Given this list of marker genes RNF138, MSI2, CTDSPL2, RAPH1, AAK1, TMEM236, DOP1B, SETD5, MTCL1, NYAP2, BMPR2, PLAG1, LATS1, KAT6A, RECK, ARIH1, XRN1 (5'-3' exoribonuclease 1), ARID1A, ANKRD10, SS18, PTGES3, SLC27A3, CREB1, ANOS1, KIF13A, ABI1, ZW10, METTL15 (NCBI Gene Id 196074), ZNF737, TMEM230 (NCBI Gene Id 29058), VDAC1, HSPD1, PPP5C, PTPRA, NT5C2, RASAL2, BCL11A, MAPK1, SHANK2 (NCBI Gene Id 654128), PRR15L, ZBTB18, FAM218A, SSR1, OCRL, PRPF39, SPG11 (NCBI Gene Id 80208), HOOK3, CAMKK1, NCAPG2, DNAJC6, NECAB1, GPR82, KRAS, TUBB2B, RPS6KB1, STK3, CHMP4B, CHRNA5 (cholinergic receptor nicotinic alpha 5 subunit), VKORC1L1, MAN2A1, TMOD2, LSMEM2, CPNE8, DCK, LRP1B, SFT2D1, APPL2, PDE4D, SCG2, ATP1A2, CAMSAP2, TGFBR3, ENTPD7, CDC73, ONECUT2, APC, TNFRSF19, PTPRD, ABL2, MYOCD, SPTY2D1, CUL2 (cullin 2), HECTD3, DYNC1H1, INPP5B, TAF1, MRPL51, SEC24A, ITM2B, SCAMP1 (secretory carrier membrane protein 1), MAPK10, GFPT1, PDS5B, KLHL5, ACP6, PRICKLE2, PPFIA2, TRIM33, EMP2, RNASE4, GAPVD1, SRSF10, CACNB4, STEAP2, TLCD4, SCAI, MSX1, METAP1, EIF4E, UBE2D2, NLK, PPP4R3A, SNX10, GRIK2, SLC12A2, RPS6KA3, YBX1, PDE7A, CCND3, CCDC102A, ADAMTS3, INO80D, TFPI2, IPO4, ZNF367, CASK, TGFB2, INTS12, TLE4, SLC23A2 (solute carrier family 23 member 2), DAB2IP, TSPAN13, CCSER1, PEG3, ZNF569, CNR1, GCLC, CDH8, CYP27C1, TBC1D19, TMCO3, MAPK8IP1, CAPZA2, REEP1, EDDM3A, HSPA13, RAB33B, NEK7, PPP1R8, ARSJ, LARP6, TRA2B, CHUK, LHX6, PRDM12, SAFB, MOB1B (NCBI Gene Id 92597), PPP1R1B, ELOVL6, ZNRF2, SGIP1, ATAD2B, ZC3H12C, KLHL24 (kelch like family member 24), SLC2A13, BZW1, RASSF8, THAP5, KHDRBS2, PPIE, ANKRD44, FOXO1, ALDH1A3, ZNF281, IKZF5, KCNN4, ADAMTS5, KLF4, RIMKLB, RNLS, MAMLD1, PTCH1, DLGAP1, UCHL5, STON2, ETV1, TAX1BP1, NAMPT (nicotinamide phosphoribosyltransferase), HMGB3, C2CD5, JMY, EIF4G2 (NCBI Gene Id 1982, eukaryotic translation initiation factor 4 gamma 2), LIPF, ZNF681, PTPN13, HAPLN1, NCSTN, PRSS12, HYCC2, ST6GALNAC3, NEGR1, COL11A1, SALL1, GLCCI1, FNDC3B, CTNNB1, NIF3L1, SV2B, C17orf75, RRM2, NT5DC1 (5'-nucleotidase domain containing 1), ZNF780A, ZIC3, EEA1, PSME4, VASH2, RAB5A, SCAP, RPGR, MEGF10, PPP6R3, ARFGEF1, COPS5, CCSER2, ITGB8, GPR180, NF1, ELOVL5, MTM1, NUP58, LCOR, TRIAP1, SCAF8, GPC6 (glypican 6), RCBTB1, SPP2, JAZF1, ASPN, NR4A2, MPP7, LSM14A, GCLM, LCLAT1, HTATIP2, ARID4B, TMEM26, CCDC186 (coiled-coil domain containing 186), PNRC2, SETMAR, FUNDC1, DHX36, RRAS2, NTN4, TRIQK, CTTNBP2NL, HMMR, HMGB1, STUB1, VGLL4, COL4A1, COL5A2, ZNF780B (zinc finger protein 780B), TBPL1, TMEM221, MEF2C, RTF1, ANKRD22, CTTNBP2, PTPRB, PROX1, CNOT2, EIF5A2, DOCK10 (NCBI Gene Id 9714), SPATA13, MPHOSPH6, RSBN1L, NAA16, NPAS2, GJC1, CSE1L, HCN1, MS4A15, LDHD, ROCK2, PLPPR5, KAT2B, PLEKHM3, IGF2R, OTUD3, GSE1, IFIT1, UBE2B, PCF11, SGK1, GRIA4, MED13, MX1, ERLIN1 (ER lipid raft associated 1), CNST, GAREM1, TFDP1, ENSG00000286190, FCHO2, CEP20, A4GNT, TBL1XR1, CNTN4, ASB1, QKI, DCAF7, SLC35A3, RAI14, MARK1, BMP7, ABTB2, MAGEA10, TAOK1, SFRP2, WIPF1, ABHD18, HIVEP2, SSMEM1, SCN8A, STAU2, GPHN, ZNF546 (zinc finger protein 546), RAPGEF6 (NCBI Gene Id 51735), NTNG1, PROKR2, PHACTR2 (NCBI Gene Id 9749), SH3BP5, RBM27, FBN1, HOXA1, PEX14, FGF9, RCHY1, ELF3, PTPN9, MEGF11, LSM11, PHF6, TNFAIP1, CYP20A1, TMEM59, MAPK8, PTPRJ, SPTBN1, ITSN1, RASGRP1, ABI3BP, LEMD3, SIAH1, ARHGAP12, PHF20, CPEB2, CLCN3, SEPTIN7, SHISA6, here is a description of the gene set: studied in species Homo sapiens from publication Chen Y, Wang X (PMID 31504780) Human Gene Set: MIR10399_5P Genes predicted to be targets of miRBase v22 microRNA hsa-miR-10399-5p in miRDB v6.0 with MirTarget v4 prediction scores > 80 (high confidence targets).